Given this list of marker genes FOSL2, NTS, CREB1, IL2, GJA1, SP1, MYB, NPPA, CRTC1, NR3C1, FABP4, CTNNB1, DMP1, COPS5, MT2A, MMP1, TRIP6, FOS, COL1A2, NFATC1, TH, NFATC3, PENK, MMP9, DMTF1, FOSB, CCN1, TGFB1, ATF3, MYC, MAFG, IL5, FOSL1, TCF7L2 (transcription factor 7 like 2), CBFB, DUSP1 (dual specificity phosphatase 1), CCND1, HIF1A, TIMP1, MAF, BCL2L11, JUN, PLAU, EGR1, CDKN2A, TP53, IFNG, ELF1, IL4, IL6, ACTA1, IL10, EP300, CDKN1B, ESR1, AGT (angiotensinogen), JUNB, ATF2, CXCL8, CSF2, BAG1, JUND, CCL2, PTEN, NFATC2, HLA-A, CDK1, EDN1, GATA2, ETS1, here is a description of the gene set: from publication Schaefer CF, Anthony K, Krupa S, Buchoff J, Day M, Hannay T, Buetow KH (PMID 18832364) Human Gene Set: PID_AP1_PATHWAY studied in species Homo sapiens AP-1 transcription factor network